The following is a description of a gene set: Mouse Gene Set: GOBP_NEGATIVE_REGULATION_OF_HIPPOCAMPAL_NEURON_APOPTOTIC_PROCESS Any process that stops, prevents, or reduces the frequency, rate or extent of cell death by apoptotic process in hippocampal neurons. species: Mus musculus, and this is the list of marker genes: Cx3cl1, Stambp, Draxin, Lcn2, Cx3cr1